Given this list of marker genes Dctn1, Hspa1b, Pde4dip, Pak1, Eml2, Hspa1a, Arhgef7, Mecp2, Git1, Ckap5, Nme7, here is a description of the gene set: Any process that modulates the rate, frequency or extent of microtubule nucleation. Microtubule nucleation is the 'de novo' formation of a microtubule, in which tubulin heterodimers form metastable oligomeric aggregates, some of which go on to support formation of a complete microtubule. Microtubule nucleation usually occurs from a specific site within a cell. Mouse Gene Set: GOBP_REGULATION_OF_MICROTUBULE_NUCLEATION studied in species Mus musculus